Given this list of marker genes IST1, TACC1, PTBP3, PPP6R3, LYVE1, KCNA4, F7, TRIM58, XG, CCDC140, UBE2D3 (NCBI Gene Id 7323), FEZ1, NLGN1, TMEM255A (transmembrane protein 255A), RNF180, TUBG1, SGTB, BPNT2, RGL1, CWC27 (NCBI Gene Id 10283), OSBPL6, KLRG1, STARD7, EML6, PLXDC2, OTUD6B, ZFHX3, TESK1, ITK, SLAIN1, SRSF7, GPR52, GPR161, TXNDC5, LIN7C, PACC1, LUZP1, HPSE2, ARMCX3, PPM1G, UBE2D2, ATP2B2, AWAT2 (acyl-CoA wax alcohol acyltransferase 2), SYNJ2BP, MRPS35, RYR2, PTX3, RAB8B, ATG12, TPT1, ZBTB44, here is a description of the gene set: Human Gene Set: MIR4474_5P studied in species Homo sapiens Genes predicted to be targets of miRBase v22 microRNA hsa-miR-4474-5p in miRDB v6.0 with MirTarget v4 prediction scores > 80 (high confidence targets). from publication Chen Y, Wang X (PMID 31504780)